Given this list of marker genes GNAI1, GNB2, ADCY2, ADCY8, GNG4, GNAT3 (NCBI Gene Id 399515), ADCY1, ADCY6, ADCY4, GNB1, GNG12, GABBR1, KCNJ4, GNGT2, ADCY5 (NCBI Gene Id 255218), KCNJ16 (potassium inwardly rectifying channel subfamily J member 16), KCNJ12, GNAI3, ADCY7, KCNJ6, KCNJ9, GNAI2, KCNJ3, GNG7, GNG8, GNGT1, KCNJ10, GNG13, GNG3, KCNJ5, GNG5, GNG2, GABBR2, GNB3, GNAL, GNG11, ADCY9, GNG10, GNB4, KCNJ15, KCNJ2, ADCY3, GNB5, here is a description of the gene set: Human Gene Set: REACTOME_GABA_B_RECEPTOR_ACTIVATION GABA B receptor activation studied in species Homo sapiens